Given this list of marker genes Ercc5, Ercc8, Pold1, Slx4, Ercc3, Xpc, Ercc1, Xpa, Xrcc1, Rad23b, Cetn2, Ercc4, Xrcc4, here is a description of the gene set: species: Mus musculus Any complex formed of proteins that act in nucleotide-excision repair. Mouse Gene Set: GOCC_NUCLEOTIDE_EXCISION_REPAIR_COMPLEX